Given this list of marker genes NDEL1, IRGM, PLK2, JAK3, MAP3K8, GAS1 (growth arrest specific 1), MYD88, MX2, ANXA3, FGF7, TBC1D10A, PRSS58, EIF1AY, CKM, PROCR, SLC12A7, SLC7A9, TEX2, ITPKB, MCOLN2, MYPOP, B4GALT3, SOCS1, CXCL10 (NCBI Gene Id 3627), IL4R, IST1, ROR1, NUP50, CYP2C19, SLC4A8, HSD11B2 (hydroxysteroid 11-beta dehydrogenase 2), LTB4R, GCNT2, FUT2, PLA2G4A, UBE2J2, RYR3, GBP4, EIF2S3, ZNF281, ALDH1A1, INPP5B, CSF1, BHLHE40, H3-4, ALDH1A2, PLCB1, ADAM9, MRAP, STAT5A, CASP4, SLC6A13, FNDC1, ARNT, KRT17, CAMK2B, MYL11, PML, SFTPB, PAK4, FABP5, PIM1, RMDN3, SERPINF2, GRINA, NOC4L, TLR6, CCL22, TRAF3IP2, PRKD2, APAF1, NEUROG1, AKIRIN1, NAMPT, ZNHIT3 (NCBI Gene Id 9326), EEA1, AIMP2, GBP7, SLC44A2, TFF1, AZIN1, INPP1, CH25H, SUSD6, CD7, CCND1, STK39, CCL2, GKAP1, TANK, IRF1, WARS1, CLCN7, IFI35, CCL13, TSPAN13, LGALS8, TIMP3, PLSCR1, UBE2S, CD244, TAP1, TMEM129, PHGDH, IL13RA1, CDCP1, ACSL1, USP18, MORF4L2, WNT1 (Wnt family member 1), SERPINA3, MYH14, IFIT2, NABP1, HAP1, SLC41A1, NSMCE1, CER1, KDR, KCNH1 (NCBI Gene Id 8656), TECTA, STX12, PNP, POLR2C, CAVIN1, VIPR2, FOXL1, C9orf72, PIM3, CACHD1, ADA, DCK, COX18, IL12B, OR13J1, CPS1, EGR2, SLFN12L, STAT3, SYT7, IFT88, AATK, NOCT, NUP62, ELK3, SELP, PSMB9, STAT1, CFB, UBE2K, PPA1, NCKAP1L, ABI1, PTPRK, SLC5A1, GCM1, RSAD2, IFITM3, BZW2, PIP5K1B, CDKN2D, MGAT1, RNH1 (ribonuclease/angiogenin inhibitor 1), HPCAL4 (hippocalcin like 4), ZNF777, SH3BGR, AGFG1, TPST1, ACADL, GBP2, CNN3, NKX2-6, DHH, SLC1A6, INHA, VCAN, C1GALT1C1, IL18BP, NDRG1, EFNA3, CCL7, TRIM21, PSMC4, ZFAND5, MC2R (NCBI Gene Id 4158), SAMHD1, SOAT2, CASP7, HSF2, LYN, PAPOLB, TIMP1, HTR2B, EMP1, MXD1, ATAD3A, PNPT1, PTGS2, NUP188, MT2A, here is a description of the gene set: Human Gene Set: GSE39864_WT_VS_GATA3_KO_TREG_UP Genes up-regulated in T reg cells: wildtype versus GATA3 knockout. The transcription factor Foxp3 is indispensible for the differentiation and function of regulatory T cells (Treg cells). To gain insights into the molecular mechanisms of Foxp3 mediated gene expression we purified Foxp3 complexes and explored their composition. Biochemical and mass-spectrometric analyses revealed that Foxp3 forms multi-protein complexes of 400-800 kDa or larger and identified 361 associated proteins ~30% of which are transcription-related. Foxp3 directly regulates expression of a large proportion of the genes encoding its co-factors. Reciprocally, some transcription factor partners of Foxp3 facilitate its expression. Functional analysis of Foxp3 cooperation with one such partner, Gata3, provided further evidence for a network of transcriptional regulation afforded by Foxp3 and its associates to control distinct aspects of Treg cell biology. Gene expression profile of Treg specific knock-out of Gata3 vs. their littermate controls were analyzed to gain insight into Gata3 dependendent genes in Treg cells. studied in species Homo sapiens from publication Rudra D, deRoos P, Chaudhry A, Niec RE, Arvey A, Samstein RM, Leslie C, Shaffer SA, Goodlett DR, Rudensky AY (PMID 22922362)